The following is a description of a gene set: species: Mus musculus from publication Chen Y, Wang X (PMID 31504780) Mouse Gene Set: MIR_381_3P Genes predicted to be targets of miRBase v22 microRNA mmu_miR_381_3p in miRDB v6.0 with MirTarget v4 prediction scores > 80 (high confidence targets)., and this is the list of marker genes: Chd2, Fam117a, Hivep1, Zfyve21, Ythdf1, Sgtb, Gramd4, Rab2a, Slc7a3, Cdk1, Pdpn, Nlgn1, Xpo7, Ralgapa2, Zbtb41, Frs2, Wee1, Kpna3, Med23, 9330159F19Rik, Dcc, Ppp3ca, Hoxa9, Med14, Jph1, Dhx33, Frmd6, Epb41l1, Foxd4, Thap1, Nup35, Nedd9, Nr0b1, Tut4 (terminal uridylyl transferase 4), Nol9, Tmem68, Phactr4, Fbxo34, Reln, Kif1b, Lrp6, Vcpip1, Ptbp3, Abca8a, Grpel2, Kif20b, Homer2, Gtf2a1, Chd9, Nmral1, Paxbp1, Itm2b, Syvn1, Taok1 (NCBI Gene Id 67240), Id1, Zfyve16, Nr5a2, Cpsf6, Tmem39a, Gfra1, Abi1 (NCBI Gene Id 214715), Zfhx3, Camta1, Prpf38b, Rfx5, Adamts3, Siglecf (NCBI Gene Id 233186), Myh10, Dek, Syt14, Trpc5, Ranbp3l, Son, Adamtsl3, Zbtb22, Parp1, Fam107b, Zmym6, Esr2, Erf (NCBI Gene Id 13875), Bltp1, Phf2, Kbtbd2 (kelch repeat and BTB (POZ) domain containing 2), Pip5k1b, Irx3, Tbc1d15, Ccr2, Col11a1, Ablim3, Dnajc27, Gjc3, Eps8, St8sia3, Emp2, Ptp4a1, Rnpc3, Dcun1d4, Fa2h, Rab39b, Cilk1, Btf3l4, Mdm1 (NCBI Gene Id 492875), Prr12, Wapl, Sp4, Suclg2, Lzts2, Sh3gl3, Mitf, Dcaf10, Lpar4, Psd3, Cnot7, G2e3, Acvr2b, Kif11, Npy, Arid4b, Cacna1c, Etl4, Sox9, Lrrc1, Pds5b, Nexmif, Skil, Fbxo45, Nktr, Jph3, Crk, Rnf2, Pnn, Chst2, B3gnt5, Atad5, Trim63, Tube1, Mblac2, Jag2, Myct1, Akap12, Ubr1, Ube3a, Ppp1r15b, Ano1, Ccdc117, Grm8, Hectd2, Dennd2b, Rnf185, Lin9, Cbx5, Cdh20, Kdsr, Spock3, Ppp1r14c, Golga2, Vezf1, Scaf8, Ocln, Iqsec2, Wnt5a, Klf4, Mphosph9, Slc6a8, Syncrip, Gad1, Zfp101, Lgr4, Zbtb18, Khdrbs2, Kctd12, Rpl22 (ribosomal protein L22), Add3, Tln2, Cwc22, Syngr3, Selenok, Trpc7, Slc38a2, Spred1, Tm9sf2, Ipo8, Zfp800, Yy1, Med13, Nbea (NCBI Gene Id 26422), Gas2, Arpp21, Actr3, Dll4, Ppp4r3b, Fbxo43, Rab10, Gpr158, Ppfia1, Wdr37, Agap1, Plekhg5, Rap2c, Pnrc1, Slain2, Cbln4, Dock11, Septin9, Pcdh8, Cry1, Ccnl2, Pcgf5, Lrrc4, Npy1r, Nptn, Dhx35, Ube2e2, Cnot6l, Nfkbia, Thbs1, Hmgxb4, Mast4, Rab6b, Cnksr3, Akap6, Stk17b, Dennd4a, Adrb2, Sorbs1, Rabggtb, Grhl3, Pi4ka, Eif4g3, Nkx2-9, Bche, Hbp1, Rybp, Lef1, Ppp1r2, Inpp5f, Xrcc2, Psip1, Foxo1, Atp6v1h, Zc3h11a, Anks1b, Kalrn, Nr3c1, Hdx, Gria3, Gtf2i, Arih1, Fut9, Dazl, Srsf1, Ppp4r2, Slmap, Gdap2, Cnpy1 (canopy FGF signaling regulator 1), Btaf1, Ncoa2, Hook3, Xpo1, Jade2, Thrb, Rab3c, Oxr1, P2ry10b, F3, Clcf1, Sgo2a, Zfpm2, Apaf1, Tusc3, Nr2f2, Trh (thyrotropin releasing hormone), Osbpl3, Gucy2f, Carmil3, Taf4b, Rsrp1, Rtn1, Zfp532, Ankrd17, Adgrg2, Met, Pdap1, Fgfr2, Ank3, Ska2, Dmtf1, Fbxo33, Zfp715, Gpc6, Clec4e, Ccng2, Stx12, Trpm7, Cnot2, Ubn1, Kras, Insm2, Ano4, Ubr5, Lrif1, Casp8ap2, Zswim4, Rnf144a, Wac, Meox2, Ubap2l, Trappc2 (trafficking protein particle complex 2), Pum2, Cadm1, Cibar1